Given this list of marker genes CTH, NACA4P, RNY3 (RNA, Ro60-associated Y3), RANBP2, NOC4L, CEP41, BMX, AQP12B, MBLAC2, MEI1, LMTK2, ICE2, RNASEH2B, CCAR1, DNAL1, BRD3OS, TEDC2-AS1, TROAP, OR14C36, PRIM2, APPBP2, HELT, GRB7, ICE1, MIR574 (microRNA 574), FAM220A, TAF8, ZNF385D, SS18, MPLKIP, TGM5, OR4K15, C2orf69, KREMEN2, here is a description of the gene set: Genes up-regulated in peripheral blood mononuclear cell vaccinated vs control in adults (18-55) (treated in vitro with wild-type MVA) after exposure to Modified Vaccinia Ankara (MVA) virus vaccine vector, time point 6H A better understanding of the relationships between vaccine, immunogenicity and protection from disease would greatly facilitate vaccine development. Modified vaccinia virus Ankara expressing antigen 85A (MVA85A) is a novel tuberculosis vaccine candidate designed to enhance responses induced by BCG. Antigen-specific interferon-gamma (IFN-gamma) production is greatly enhanced by MVA85A, however the variability between healthy individuals is extensive. In this study we have sought to characterize the early changes in gene expression in humans following vaccination with MVA85A and relate these to long-term immunogenicity. Two days post-vaccination, MVA85A induces a strong interferon and inflammatory response. Separating volunteers into high and low responders on the basis of T cell responses to 85A peptides measured during the trial, an expansion of circulating CD4+ CD25+ Foxp3+ cells is seen in low but not high responders. Additionally, high levels of Toll-like Receptor (TLR) 1 on day of vaccination are associated with an increased response to antigen 85A. In a classification model, combined expression levels of TLR1, TICAM2 and CD14 on day of vaccination and CTLA4 and IL2Ralpha two days post-vaccination can classify high and low responders with over 80% accuracy. Furthermore, administering MVA85A in mice with anti-TLR2 antibodies may abrogate high responses, and neutralising antibodies to TLRs 1, 2 or 6 or HMGB1 decrease CXCL2 production during in vitro stimulation with MVA85A. HMGB1 is released into the supernatant following atimulation with MVA85A and we propose this signal may be the trigger activating the TLR pathway. This study suggests an important role for an endogenous ligand in innate sensing of MVA and demonstrates the importance of pattern recognition receptors and regulatory T cell responses in determining the magnitude of the antigen specific immune response to vaccination with MVA85A in humans. Human Gene Set: MATSUMIYA_PBMC_MODIFIED_VACCINIA_ANKARA_VACCINE_AGE_18_55YO_VACCINATED_VS_CONTROL_TREATED_IN_VITRO_WITH_WILD_TYPE_MVA_6HR_UP from publication Matsumiya M, Stylianou E, Griffiths K, Lang Z, Meyer J, Harris SA, Rowland R, Minassian AM, Pathan AA, Fletcher H, McShane H (PMID 23844129) species: Homo sapiens